Given this list of marker genes BBS4, CENPJ, RAB11FIP3, ATMIN, SEPTIN9, MARK4, MNS1, TAPT1, CEP120, CEP135, FUZ, KCTD17, ENTR1, HTT (huntingtin), SEPTIN7, CROCC, ARHGAP35, CCDC88A, RP1, GSK3B, CCP110, IFT88 (intraflagellar transport 88), IFT20, SAXO1, WRAP73, HAP1, TTBK2, ZMYND10, DZIP1, PPP1R35, here is a description of the gene set: Any process that activates or increases the frequency, rate or extent of the formation of a cilium. species: Homo sapiens Human Gene Set: GOBP_POSITIVE_REGULATION_OF_CILIUM_ASSEMBLY